Given this list of marker genes CCDC9, TFAP2B, GNA15, UNG, PFKFB2, NRG2, ACR, CD3D, MSH2, PRPF19, CD22, MTHFR, TPX2, CXCL2, SV2A, RGS10, S100A8, RRP7A, MLLT11, GPSM3, PDGFRA, CCL3, TBX1, FADS1, SLC7A11, FOS (NCBI Gene Id 2353), RCC1, TNFRSF10C, CCNB1, CDK1, MAD2L1, PCLAF, AGXT, MCRS1 (microspherule protein 1), MYBL2, DBP, BMP10, RFC3, GAGE12F, POLD2, ZMYM3, GLRX, CLDN9, LRIT1, RFC4, CCL7, CD33, SLC22A18AS, ADA, ANXA1, ATP4A, H2AX, KIF2C, PARP2, LAIR1, PKMYT1, KIF14, AQP8, ODF1, KNTC1, SAC3D1, TMX1, GGH, ARHGAP4, NMB, IL32, CCND2, SYNGR4, LCP1, OLFML2B, FOXM1, MDK, LMNB1, GTF2H3, FST, RECQL5, SERBP1, CFP, CCNB2, MAGI1, CCL5, CDKN3, SLC7A5, IFIT1, RAB31, CD53, CYP1B1, CDK2, IGHG3, ETS2, EPB41L3, DBN1, GFPT2, DDIT4, SALL2, ANPEP, S1PR4, EEF1E1, IGFBP2, KCNQ3, DNMT1, CCL4, CRABP1, ENO2, ALOX5AP, GREM1, RRP9, EMP3, HCLS1, ILF3 (interleukin enhancer binding factor 3), SPINK2, SLC6A11, AIF1, GET1, GALR3, ITGA10, RIBC2, PLAU, CCNF, CKS2 (CDC28 protein kinase regulatory subunit 2), CXCR4, SHMT2, H4C3, IER3, MCM3, SLC6A7, HTR4, DHFR, FADS2, EFNA2, KRT4, AANAT, NCAPD2, RBM38, KRT86, MAT1A, RCN2, METAP1, ITGB2, ATF5, SULT4A1, NUP205, GLA, PSMB8, ACKR1, BOP1, ID2B, PEG10, SFTPC, MCM6, EDA, PRIM1, VSIG4, LIPA, EXOSC2, HPRT1, IRAG2, NPM3, JUN, H2BC12, GINS1, MSI1, CREG1, PSPHP1, KLHDC3, PTPRC, ARHGEF6, TYR, RGS16, CSE1L, PECAM1, TMSB15A, SOX10, JUNB, DVL1, CDC45, ST6GALNAC4, HAP1, LIF, LGR5, IGF2BP3, DLGAP5, LGALS9, TNF, TOP2A, RGS1, IL7R, LMNB2, PTPN7, CEP135, TTI1, TMEM106C, POU4F1, BUB1B, TROAP, MYOZ3, ATF3, SYNCRIP, SCN2B, WNT10B, UBE2C, IKBKG, LRCH4, ARHGDIB, CORO1A, SLC2A1, DNASE1, DUSP5, SRGN, NTNG1, CHST15, MCM2, PIM2, PRB4, DMBT1, ME2, CTSG, SRPK3, BLM, ECE2, IL2RG, KCND3, CTSC, CDH2, TAP1, RNASEH2A, RRP1B, MACIR, STMN1, QSOX1, CDC20, CD79A, CHPF, GMPS, TMSB4Y, CDKN2C, ADSL, SLA, PER1, ELAVL2, E2F1, DAPK2, LST1, MMP2 (matrix metallopeptidase 2), MAPK12, TOPBP1, MNDA, CENPA, EIF4EBP1, VPS11 (VPS11 core subunit of CORVET and HOPS complexes, NCBI Gene Id 55976), PLIN2, UCN, CD24, SERPINE1, ZNF22, PTP4A3 (NCBI Gene Id 11156), CCNA2, ARID1A, CLEC3B, ACD, PAICS, PPP4R2, ADAM19, PROC, RECQL4, SOX4, PAX6, PCDH9, LRP3, KIFC1, TYMS, RAD54L, CCL2 (C-C motif chemokine ligand 2), FEN1, DPH2, SRPK1, FDPS, HTRA2, KDM5D, PAFAH1B3, RAC2, DDX11, ENTPD2, EPAS1, MCM4, CBX1, DKK4, DDX21 (DExD-box helicase 21), EZH2 (NCBI Gene Id 392834), WEE1, S100A4, PRKDC, PAX7, ATOSB (NCBI Gene Id 80256), MLC1, INSIG1, RRM2, CCHCR1, DOCK2, CDK6, MSH6, CSNK2A1, HMMR, APOC4, RAC3, MAGEA4, PRAME, MFAP2, MYC, HAT1, S100P, PTTG1, ASNS, M6PR, TRPM2, SHBG, IGHM, CST7, NPAS1, LBP, WIZ, AP1M1, TACC2, BCL2A1, GPR3, KIF11, POLD3, NECTIN1, CASP2, CKAP5, TCL1A, FCER1G, HLA-DMA, ABCA1, RRM1, DDX3Y, FGR, KCTD17, ZIC2, AMELX, IGKC, RHBDL1, GNG7, PNP, CARD10, EXD2, CENPF, DTYMK, FZR1, SWAP70, KIF21B, CDC25B, ISG15, ZBED4, GTSE1, S100A11, BASP1, ZYX, FOSB, PCNA, MYB, SH3BP1 (SH3 domain binding protein 1), PLK1, CD3E, CNKSR1, CSTA, COPS3, LSP1, CDC7, LPAR2, PRELID3A, MMP9, BIK, ARTN, MKI67, ORM2, SIT1, CLEC2B, KCNN4, ATP2A3, LAPTM5, RPA3, RPA1, MPO, CD69, TRIP13, NUDT1, SSTR2, GSTM1, HLA-DQA1, ABCB9, SCAMP5, DNTT, CD37, LMO2, CHAF1A, ZWINT (ZW10 interacting kinetochore protein), UBE2L6, SIX6, NDC80, AK2, HCK, TNFRSF10D, COL10A1, here is a description of the gene set: Human Gene Set: MODULE_53 species: Homo sapiens Cell line expressed genes.